The following is a description of a gene set: studied in species Mus musculus Mouse Gene Set: GOBP_NEGATIVE_REGULATION_OF_PROTEIN_BINDING Any process that stops, prevents, or reduces the frequency, rate or extent of protein binding., and this is the list of marker genes: Akt1, Dnajb2, Frmd7, Kdm1a, Pcsk9, Ptprf, Tmc8, Cdkn1a, Gtf2f1, Adam15, Tmbim6 (transmembrane BAX inhibitor motif containing 6), Styx-ps, Gnl3l, Plscr1, Myc, Park7 (NCBI Gene Id 57320), Tex14, Pdgfb, Slpi, Aurka, Sympk, Ifit2, Bax, Tfip11, Shh, Stub1, Styx, Itga4, Atp2a2, Il10, Ttc36, Mapk3, Mitd1, B2m (beta-2 microglobulin), Rgma, Pin1rt1, Rack1, Ddx11, Ccm2l, Aurkb, Nes, Pex14, Hfe, Dtnbp1, Xirp1, Usp33, Crtac1, Nog, Ttbk2, Lrpap1, Wfikkn1, Dact1, Psme3ip1, Efhb, Golga2, Dkk1, Dhrs7b, Ralb, Cdkn2a, Ttbk1, Itgb1bp1, Pabpn1l, Nfatc4, Tdg, Ctnnbip1, Rock1, Pin1 (peptidyl-prolyl cis/trans isomerase, NIMA-interacting 1), Dab2, Camk1, Epb41l5, Wfikkn2, Lrrk2, Ckmt1, Pim2, Zfpm1, Tle5, Carm1, Atp2a3, Mapk8, Bag2, Adipoq